The following is a description of a gene set: studied in species Homo sapiens Human Gene Set: GSE7764_IL15_NK_CELL_24H_VS_SPLENOCYTE_DN Genes down-regulated in comparison of NK cells treated with IL15 versus total splenocytes. from publication Fehniger TA, Cai SF, Cao X, Bredemeyer AJ, Presti RM, French AR, Ley TJ (PMID 17540585) Murine NK cells were compared at rest and following 24 hours of IL-15 stimulation for their mRNA expression profiles on the Affymetrix MOE430_2 microarray platform. Additional comparators included resting bulk splenocytes., and this is the list of marker genes: UQCR10, SNAP29, CPQ, PSMC6, PECAM1, BCL9, ACTN1, RPL4, KLF2, RBM5, KLHL7, CDK2AP2, MTERF3, TMA16, FBRS, IFITM2, PPP4R2, CD300C, STK38, C9orf72, UBAP1, KLF4, CD72, MAT2B, CTSZ, SLC46A3, AGO4, SATB1, JAK1, RPS4X, RGCC, EPOR, FAM53B, PDE7A, RGS19, MARCKSL1, SLC25A30, STAMBPL1, CD300LD, IRGM, BDH1, RPL36A, CD3G, EP300, CCDC97, HERC4 (HECT and RLD domain containing E3 ubiquitin protein ligase 4), CHFR, ANG, PACSIN1 (NCBI Gene Id 57564), SPOP, STK4, HSH2D, PICALM, RAB3IL1, ITGA4, COQ8A, SLC3A2, RGS2, KANSL2, TFEC, TMEM108, PPARG, NDST1, AHCYL2, ERO1B, RFLNA, KGD4, SNX5, NUAK2, TRIB2, EDEM1, GPR35, SRSF6, ZFP36, PLA2G12A, TMEM50B, MARCHF7, MYO1C, EPB41L2, FABP4, CDC26, DNAJC7, TPCN1, FYB1, RASSF4 (Ras association domain family member 4), RABAC1, SMAD4, MINDY2, SERINC1, MOB2, FUOM, PAG1, JMJD1C (NCBI Gene Id 9323), TMT1A (NCBI Gene Id 25840), FBXO33, UVSSA, TSPAN32, YPEL3, EVA1B (eva-1 homolog B), PCK2, ATP10D, RNF167, SDCBP, HMOX1 (heme oxygenase 1), MS4A7, USP15 (ubiquitin specific peptidase 15), EMG1, WDTC1, INSR, MEFV, SNHG6, CLCN5, FFAR2, TG, HSD17B11, APOBEC3B, ADI1, IRF9, IP6K2, RNF139, FGFR1OP2, UNC93B1, TGFBR3, IGF1, SORT1, GIMAP6, IFRD2, KAT6A, STK17B, SGK3, TUT7, RETREG1, IFI27, LTB4R, AKIRIN2, RAPGEF4, ARHGEF12, NINL, CD4, DYNLL1, MXI1, PARP1, ANK1, HSPBAP1, FBXO38, CAMK4, MYL4, ADGRE5, PILRA, STRN4, UROD, RPL17, MLXIP, ARHGEF18, INVS, TP53INP1, XKRX, ANAPC10, ZNF280D, GRAP, SELENOK, FTH1, MCL1, RIPOR2, MCOLN3, PRKCD, TFRC, SIRPA, XAF1, BACH2, ARHGAP30, RELCH, MT2A, SDC1, NIPBL, IRF5, PTPRO, CST3, FTL, DCTN5, RSU1, CYTH1, PLCG2, DCUN1D1, RPS6, OTUD5, XXYLT1, FRY, PKD1, NCOA3, HUWE1, TXNIP, HIPK1, TMEM131, SMC4, CELF1, BCL2A1, PHIP, FZR1